Given this list of marker genes FGF4, MSX1, TFAP2C, TCF7L1, TFAP2B, BMP4, SOX2, GBX2, DLX5 (NCBI Gene Id 80275), MYB, TFAP2A, WNT3A, PAX3, POU5F1, ZIC1, PAX7, CTNNB1, here is a description of the gene set: Specification of the neural plate border studied in species Homo sapiens Human Gene Set: REACTOME_SPECIFICATION_OF_THE_NEURAL_PLATE_BORDER